The following is a description of a gene set: studied in species Homo sapiens Human Gene Set: HP_CARDIOMYOCYTE_HYPERTROPHY An increase in cell size, enhanced protein synthesis, and heightened organization of the sarcomere within cardiac myocytes. Cardiomyocyte hypertrophy, and this is the list of marker genes: GYG1, ACTC1, DSP, ALPK3, ACTN2 (NCBI Gene Id 88), VCL, DOLK, KLHL24, TNNI3